Given this list of marker genes Pml (promyelocytic leukemia), Pparg, Cyp26b1, Nr1h2, Crkl, Akr1c18, Zfp536, Rarg, Rarb, Calr, Klf9, Dhrs3, Ptf1a, Aldh1a3 (NCBI Gene Id 56847), Actn4, Tgif1, Rxrb (NCBI Gene Id 20182), Nr2c1, Cnot1, Asxl1, Snw1, Sp1, Thrb, Greb1l, Aldh1a2, Esrrg (NCBI Gene Id 26381), Ctbp2 (C-terminal binding protein 2), Klf2, Cyp26a1, Rxra, Rara, Vdr, Rxrg (NCBI Gene Id 20183), Strap, Tbx1, Thra, Ezh2, Kmt2e, here is a description of the gene set: studied in species Mus musculus A nuclear receptor-mediated signaling pathway initiated by a retinoic acid binding to an intracellular receptor of the nuclear receptor protein family, and ending with regulation of a downstream cellular process, e.g. transcription. Mouse Gene Set: GOBP_RETINOIC_ACID_RECEPTOR_SIGNALING_PATHWAY